Given this list of marker genes NEIL3, PIK3CG, F8A1, BARD1, FAM111B, PPIL2, TTLL12, FAM111A, EID2B, CDC20, CDK2AP2, SKP2 (NCBI Gene Id 86997), AURKA, PAGR1, ZNF280D, RARA-AS1, ESPL1, CCNA2, GEMIN6, KIFC1 (NCBI Gene Id 95229), PLCXD1, EXOSC2, LYL1, ZNF174 (zinc finger protein 174), CBX2, RRS1, TACC3, NXF1, DHRS3, NIF3L1, TMPO, ELOVL6, BUB1B, TIMM8A, CCDC51 (coiled-coil domain containing 51), PLK1 (polo like kinase 1), DDX28, MKI67, CCNF, ZNF93, ENOSF1, PPP1R35, SGO2, E2F8, ARMCX4, TREX1, OSGEPL1, KIF15, PRMT7, NR2F6, NDC80, CDKN2C, XAF1, POLR3B, SPC24, PML, here is a description of the gene set: Genes from the turquoise module which are dn-regulated in HAEC cells (primary aortic endothelium) after exposure to the oxidized 1-palmitoyl-2-arachidonyl-sn-3-glycerophosphorylcholine (oxPAPC). Human Gene Set: GARGALOVIC_RESPONSE_TO_OXIDIZED_PHOSPHOLIPIDS_TURQUOISE_DN studied in species Homo sapiens from publication Gargalovic PS, Imura M, Zhang B, Gharavi NM, Clark MJ, Pagnon J, Yang WP, He A, Truong A, Patel S, Nelson SF, Horvath S, Berliner JA, Kirchgessner TG, Lusis AJ (PMID 16912112) Oxidized phospholipids are thought to promote atherogenesis by stimulating endothelial cells (ECs) to produce inflammatory cytokines, such as IL-8. In studies with mouse models, we previously demonstrated that genetic variation in inflammatory responses of endothelial cells to oxidized lipids contributes importantly to atherosclerosis susceptibility. We now show that similar variations occur in cultured aortic ECs derived from multiple heart transplant donors. These variations were stably maintained between passages and, thus, reflect either genetic or epigenetic regulatory differences. Expression array analysis of aortic EC cultures derived from 12 individuals revealed that >genes were regulated by oxidized phospholipids. We have used the observed variations in the sampled population to construct a gene coexpression network comprised of 15 modules of highly connected genes. We show that several identified modules are significantly enriched in genes for known pathways and confirm a module enriched for unfolded protein response (UPR) genes using siRNA and the UPR inducer tunicamycin. On the basis of the constructed network, we predicted that a gene of unknown function (MGC4504) present in the UPR module is a target for UPR transcriptional activator ATF4. Our data also indicate that IL-8 is present in the UPR module and is regulated, in part, by the UPR. We validate these by using siRNA. In conclusion, we show that interindividual variability can be used to group genes into pathways and predict gene-gene regulatory relationships, thus identifying targets potentially involved in susceptibility to common diseases such as atherosclerosis.